Given this list of marker genes GDPD5, PLCL1, PLCL2, NOTUM, PLCH2, CASR, PLCD4, F2RL2, EDNRA, PLCE1, PLCD1, PLCB1, CCL5, CHRM3, PLCH1, PLCD3, SMPD1, CCR5, PLCB4, PLCB2, CHRM1, PLCG1, PLCB3, CHRM5, PDGFRA, BDKRB2, PLCG2, PDIA3, CCR1, PLCZ1, PDGFRB, HRAS (HRas proto-oncogene, GTPase), here is a description of the gene set: Catalysis of the reaction: a phospholipid + H2O = 1,2-diacylglycerol + a phosphatidate. Human Gene Set: GOMF_PHOSPHOLIPASE_C_ACTIVITY studied in species Homo sapiens